Given this list of marker genes Prkag3, Ep300, Ier3, Ins2, Flcn, Mlxipl, Il3, Rptor, Git1 (NCBI Gene Id 63992), Eif6, Gck, Htr2a, Slc2a6, Hif1a, Sik2, Prkag2, Tigar, Cbfa2t3, Myog, Prxl2c, Mtch2, Zbtb7a, Nupr1, Arl2 (ADP-ribosylation factor-like 2), Gpi1, Stat3 (NCBI Gene Id 68733), App, Ncor1, Gpd1, Pfkfb1, Hdac4, Actn3, Ogt, Ifng, Prkaa2 (NCBI Gene Id 66516), Sirt6, Ppara (peroxisome proliferator activated receptor alpha), Zbtb20, Uchl1, Ppp2ca, Ddit4, Igf1, Myc, Jmjd8, Trim63, Prkaa1, Gapdhs, Kat2b, Ppargc1a, Mlst8, Ins1, Psen1, Mlx, Insr, Prkaca, Prkag1, Src, P2rx7, Slc4a1, Mtor, Trex1, Esrrb, Fbp1, Slc4a4, Arnt, here is a description of the gene set: Mouse Gene Set: GOBP_REGULATION_OF_GLYCOLYTIC_PROCESS studied in species Mus musculus Any process that modulates the frequency, rate or extent of glycolysis.